The following is a description of a gene set: There is widespread interest in efficient characterization of differences between tumor and normal samples. Here, we show an effective methodology for genome-scale characterization of tumors. Using matched normal and tumor samples from liver cancer patients, as well as non-cancer-related normal liver tissue, we first determined changes in gene expression as monitored on RNA expression arrays. We identified several hundred mRNAs that were consistently changed in the tumor samples. To characterize the mechanisms responsible for creation of the tumor-specific transcriptome, we performed chromatin immunoprecipitation on microarray experiments to assay binding of RNA polymerase II, H3me3K27, and H3me3K9 and DNA methylation in 25,000 promoter regions. These experiments identified changes in active and silenced regions of the genome in the tumor cells. Finally, we used a virtual comparative genomic hybridization method to identify copy number alterations in the tumor samples. Through comparison of RNA polymerase II binding, chromatin structure, DNA methylation, and copy number changes, we suggest that the major contributor to creation of the liver tumor transcriptome was changes in gene copy number. from publication Acevedo LG, Bieda M, Green R, Farnham PJ (PMID 18413731) Human Gene Set: ACEVEDO_NORMAL_TISSUE_ADJACENT_TO_LIVER_TUMOR_UP Genes up-regulated in normal tissue adjacent to liver tumor, compared to the normal liver samples. studied in species Homo sapiens, and this is the list of marker genes: NISCH, FAM162A, MYO18A, IFT74, UQCRH, CHKA, ZFP36L1, SUMO2, NUCKS1, GCN1, ADPRM, SORT1, NADK2, HES1, PON2, GADD45G, ZNF14, MRPL51, FBXO2 (NCBI Gene Id 4930), LAP3, EDEM2, CDHR2, RPLP1, GMFG, SLPI, ABCB11, ACSM5, SPDYE3, ARMC1, CYP3A5, FRG1, PCMTD1, RPL23, SESN2, MARCKS, LIPG, PTGES3 (prostaglandin E synthase 3), DYNLRB1, PLA1A, TBPL1, RPL27A, NAT8B, USP49 (NCBI Gene Id 25862), PERP, PHF3 (PHD finger protein 3), RPL7A, RIC8B, FAM98A, ITGAV, ATG16L1, RPS3A, SLC25A51, ZPR1, LMAN2, CHD1, PNMA3, RPL14, MYCBP2, SYAP1, GSTA4, HLA-DRB3, IGBP1, AFM, UAP1, PIK3AP1, WSB2, LY96, H1-2 (NCBI Gene Id 3006), SACM1L, RAB33B, TSPAN8, SCYL2, TMT1A, FAM200A, PCTP, COX14, MICU2, RPN2, MTPN, MYO1B, EIF3A, RBM34, SH3YL1, TRIP12, FKBP5, C9, SLC17A4, SESN1, CISD1, YRDC, RBM5, CUX2, MT1P3, SAR1A, IMPA1, SHROOM3, SEPTIN11, MET, RGS2, ARPC5, GPX2, RNH1, SPIRE1 (NCBI Gene Id 56907), PLEKHA5, F11R, ZNF266, ANGEL2, HDAC2, TRIT1, GAK, ACTR3, ZNF721, GORASP1, PNN, RBM6, SLC51A, HNRNPH3, CYP51A1, ZNF212, HNRNPA2B1, C7orf50, GNA13, PGAM4, OS9, HLA-B, MBL2, RMDN1, ALG5, AHSA2P, PNISR, NTAN1, HCFC1, RPL7, YAP1, UBE2V2, SLC15A1, CFHR2, FGL1, CTSO, EIF2AK4, SNX29P1, SBDS, ACSL4, DCTN4, CYP3A7 (NCBI Gene Id 1551), C4orf33, CCAR1, DDX27, DPP4, ERGIC2 (NCBI Gene Id 51290), PEX3, TMEM37, HHEX, IDO2, MINDY3, HMGN4, EMC7, UGT2B28, TDRD1, ALCAM, APOM, PRKAB2, A2M, AHCTF1, GTF3C6, DNM1P46 (NCBI Gene Id 441735), PTMA, BLVRB, ZDHHC11 (NCBI Gene Id 79844), ELOVL5, COL3A1, M6PR, IGSF6